Given this list of marker genes SOX6, FGFR2, IL11RA, RAB23, RECQL4, MEGF8, TWIST1, here is a description of the gene set: Oxycephaly (from Greek oxus, sharp, and kephalos, head) refers to a conical or pointed shape of the skull. Oxycephaly species: Homo sapiens Human Gene Set: HP_OXYCEPHALY